The following is a description of a gene set: Genes up-regulated after Cre-lox knockout of LSD1 in pituitary. species: Mus musculus Precise control of transcriptional programmes underlying metazoan development is modulated by enzymatically active co-regulatory complexes, coupled with epigenetic strategies. One thing that remains unclear is how specific members of histone modification enzyme families, such as histone methyltransferases and demethylases, are used in vivo to simultaneously orchestrate distinct developmental gene activation and repression programmes. Here, we report that the histone lysine demethylase, LSD1--a component of the CoREST-CtBP co-repressor complex--is required for late cell-lineage determination and differentiation during pituitary organogenesis. LSD1 seems to act primarily on target gene activation programmes, as well as in gene repression programmes, on the basis of recruitment of distinct LSD1-containing co-activator or co-repressor complexes. LSD1-dependent gene repression programmes can be extended late in development with the induced expression of ZEB1, a Krüppel-like repressor that can act as a molecular beacon for recruitment of the LSD1-containing CoREST-CtBP co-repressor complex, causing repression of an additional cohort of genes, such as Gh, which previously required LSD1 for activation. These findings suggest that temporal patterns of expression of specific components of LSD1 complexes modulate gene regulatory programmes in many mammalian organs. from publication Wang J, Scully K, Zhu X, Cai L, Zhang J, Prefontaine GG, Krones A, Ohgi KA, Zhu P, Garcia-Bassets I, Liu F, Taylor H, Lozach J, Jayes FL, Korach KS, Glass CK, Fu XD, Rosenfeld MG (PMID 17392792) Mouse Gene Set: WANG_LSD1_TARGETS_UP, and this is the list of marker genes: Tgfb2, Pycard, Six1, Igfbp5, Foxg1 (NCBI Gene Id 73022), Gadd45g, Igfbp2, Mdk, Heph, Cdkn1c, Rps4l, Lgals1, Mycl, Epb41l2, Gas6, Mgp, Cd1d1, Rprm, Ezr, Elk3, Ccne1, Pdgfa, Sox2, Csrp2, Reln